The following is a description of a gene set: A congenital cataract in which opacity is limited to layers of the lens external to the nucleus (i.e., the perinuclear region), i.e., between the nuclear and cortical layers of the lens. Lamellar cataract species: Homo sapiens Human Gene Set: HP_LAMELLAR_CATARACT, and this is the list of marker genes: MIP, BFSP1, CRYBA4, CRYGS (NCBI Gene Id 1427), HSF4, CRYGB